The following is a description of a gene set: Mouse Gene Set: GOBP_MRNA_METHYLGUANOSINE_CAP_DECAPPING studied in species Mus musculus Cleavage of the 5'-methylguanosine-cap of an mRNA. The methylguanosine-cap is present at the 5'-end of eukaryotic mRNAs. Decapping inactivates translation initiation and promotes 5'-to-3' decay of mRNA., and this is the list of marker genes: Patl1, Dcp2, Dcps, Eif4enif1 (eukaryotic translation initiation factor 4E nuclear import factor 1), Cnot7, Edc3, Caprin1, Pan3, Patl2, Lsm1, Dcp1a, Zfp36, Noct (nocturnin), Nudt12, Dcp1b, Edc4